The following is a description of a gene set: studied in species Mus musculus Mouse Gene Set: GOBP_REGULATION_OF_T_HELPER_CELL_DIFFERENTIATION Any process that modulates the frequency, rate or extent of T-helper cell differentiation., and this is the list of marker genes: Anxa1, Zc3h12a, Gata3, Il23a, Ccl19, Il2, Rc3h2, Ccr2, Cd69, Lgals1, Ascl2, Tnfsf18, Foxp3, Ccl20, Mir301, Nfkbid, Il27, Irf1, Pf4, Hlx, Loxl3, Nlrp3, Socs5, Nfkbiz, Mir326, Zbtb7b, Il6, Tbx21, Tnfsf4, Jak3, Bcl6, Il4, Ccr7 (NCBI Gene Id 12775), Il4ra, Shb, Malt1, Rara, Zfp35, Ripk2, Brd2, Prkcz, Opa1, Ccr6, Il18, Smad7, H2-Ea, Ep300, Brd4, Rc3h1